The following is a description of a gene set: Catalysis of the reaction: H2O + L-arginyl- = L-citrullyl- + NH4+, resulting in citrullination of the target protein. This reaction is calcium-dependent. species: Mus musculus Mouse Gene Set: GOMF_PROTEIN_ARGININE_DEIMINASE_ACTIVITY, and this is the list of marker genes: Padi6, Padi3, Padi1, Padi2, Padi4